The following is a description of a gene set: An action or movement due to the application of a sudden unexpected stimulus. Human Gene Set: GOBP_STARTLE_RESPONSE studied in species Homo sapiens, and this is the list of marker genes: MECP2, PTEN, GRIN2A, GRID2, CNTNAP2, GRIN2D, KCNA1, DRD2, GLRA1, PENK, PRKN (NCBI Gene Id 8004), ADORA2A, DRD3, DVL1, GRIN3A, DRD1, NPR2, SLC6A3, NPAS1, CHD8, GLRB, UCN, CSMD1, COMT (NCBI Gene Id 1312), CTNNA2, TUBA1A, SLITRK6, BACE1